The following is a description of a gene set: A protein complex composed of enzymes and accessory factors of the ubiquinone (CoQ) biosynthesis pathway. In E. coli, the complex is composed of seven proteins: UbiE, F, G, H, I, J and K. In eukaryotes, the complex is located on the matrix face of the inner mitochondrial membrane and includes COQ3, COQ4, COQ5, COQ6, COQ7, COQ9. Human Gene Set: GOCC_UBIQUINONE_BIOSYNTHESIS_COMPLEX species: Homo sapiens, and this is the list of marker genes: COQ5, COQ7, COQ9, PDSS2, COQ6, PDSS1, COQ3, COQ4